Given this list of marker genes FGF10, FGFR2, NKX3-1, TNF, SHH, here is a description of the gene set: Human Gene Set: GOBP_EPITHELIAL_CELL_PROLIFERATION_INVOLVED_IN_SALIVARY_GLAND_MORPHOGENESIS The multiplication or reproduction of epithelial cells of the submandibular salivary gland, resulting in the expansion of a cell population and the shaping of the gland. species: Homo sapiens